Given this list of marker genes GNAQ, ACSL3, CD36, GNA15, PLCB1, PLCB3, GNA11, PLCB2, GNA14, ACSL4, FFAR1, here is a description of the gene set: Free fatty acids regulate insulin secretion Human Gene Set: REACTOME_FREE_FATTY_ACIDS_REGULATE_INSULIN_SECRETION studied in species Homo sapiens